The following is a description of a gene set: electronically inferred by orthology from the curated human pathway part of: FOXO-mediated transcription studied in species Mus musculus Reactome Pathway: Regulation of FOXO transcriptional activity by acetylation This event has been computationally inferred from an event that has been demonstrated in another species.<p>The inference is based on the homology mapping from PANTHER. Briefly, reactions for which all involved PhysicalEntities (in input, output and catalyst) have a mapped orthologue/paralogue (for complexes at least 75% of components must have a mapping) are inferred to the other species., and this is the list of marker genes: Ep300 (E1A binding protein p300), Sirt1